The following is a description of a gene set: species: Mus musculus Mouse Gene Set: REACTOME_SIGNALING_BY_PTK6 Signaling by PTK6, and this is the list of marker genes: Cdk4, Elmo1, Pxn, Gpnmb, Ubb, Khdrbs3, Btc, Ereg, Socs3, Cdkn1b, Rps27a, Cbl (NCBI Gene Id 12402), Hif1a, Uba52, Stap2, Dok1, Rhoa, Bcar1, Elmo2, Ccne1, Rac1, Egfr, Lrrk2, Sfpq, Uba52rt, Egf, Ptpn1, Dock1, Erbb2, Arap1, Cdk2, Erbb3, Arhgap35, Kras, Khdrbs1, Rasa1, Ubc, Hbegf, Akt1, Srms, Ptk6, Erbb4, Nrg3, Ccnd1, Hras, Crk, Nrg1, Stat3, Khdrbs2